Given this list of marker genes MX1, PSPH, ERAP2, IFI44L, EGR1, PDP1, KDELR2, here is a description of the gene set: Human Gene Set: LI_PBMC_ZOSTAVAX_AGE_25_40_AND_60_79YO_3DY_UP Herpes zoster (shingles) causes significant morbidity in immune compromised hosts and older adults. Whereas a vaccine is available for prevention of shingles, its efficacy declines with age. To help to understand the mechanisms driving vaccinal responses, we constructed a multiscale, multifactorial response network (MMRN) of immunity in healthy young and older adults immunized with the live attenuated shingles vaccine Zostavax. Vaccination induces robust antigen-specific antibody, plasmablasts, and CD4<sup>+</sup> T cells yet limited CD8<sup>+</sup> T cell and antiviral responses. The MMRN reveals striking associations between orthogonal datasets, such as transcriptomic and metabolomics signatures, cell populations, and cytokine levels, and identifies immune and metabolic correlates of vaccine immunity. Networks associated with inositol phosphate, glycerophospholipids, and sterol metabolism are tightly coupled with immunity. Critically, the sterol regulatory binding protein 1 and its targets are key integrators of antibody and T follicular cell responses. Our approach is broadly applicable to study human immunity and can help to identify predictors of efficacy as well as mechanisms controlling immunity to vaccination. from publication Li S, Sullivan NL, Rouphael N, Yu T, Banton S, Maddur MS, McCausland M, Chiu C, Canniff J, Dubey S, Liu K, Tran V, Hagan T, Duraisingham S, Wieland A, Mehta AK, Whitaker JA, Subramaniam S, Jones DP, Sette A, Vora K, Weinberg A, Mulligan MJ, Nakaya HI, Levin M, Ahmed R, Pulendran B (PMID 28502771) Genes up-regulated in peripheral blood mononuclear cell 3d vs 0d in adults (25-40/60-79) after exposure to Zostavax, time point 3D studied in species Homo sapiens